The following is a description of a gene set: studied in species Homo sapiens Abnormality of retinal pigmentation Human Gene Set: HP_ABNORMALITY_OF_RETINAL_PIGMENTATION, and this is the list of marker genes: CHM, OCA2, PEX1, TTLL5, DYNC2LI1, UNC119, GMPPB, EYS, ACOX1, MT-ND1, HCCS, PITPNM3, TUBGCP4, PDE6A, MTTP, OPN1MW, WRN, PRPH2, SDHAF1, MT-TK, MSTO1, PEX19, POLR3A, MPV17, RD3 (RD3 regulator of GUCY2D), MKS1, GSS, TRAF3IP1, HK1, ERCC6, ARL2BP, CABP4, MT-TV, ERCC2, MED12, PEX11B (peroxisomal biogenesis factor 11 beta), ATXN7, RPE65, GNAT1, CEP120, FKRP, NRL, CFH, CFAP418, CLCC1, COX8A, TAF2, SOX2 (SRY-box transcription factor 2), MT-TL1, PROM1, RAX2, NCAPG2, AIRE, PRPF3, PHYH, VPS13B, BBS5 (NCBI Gene Id 428), TRIM37, ARSG, PEX13, PCYT1A, COX7B, EDNRB, RBP3, RNASEH1, LCA5, MFSD8, PDE6H, TTC21B, ZNF408, GPR179, TUBGCP6, ARL3, CNGB1, CNGA1, NR2E3, PEX16, SAG, TBC1D20, ALDH1A3, NDUFB11, CP, ARL13B, CACNA2D4 (NCBI Gene Id 93589), PRPF31, NPHP4, IFT43, RMRP, MMACHC (metabolism of cobalamin associated C), HADHB, TRNT1, LARGE1, BBS1, WFS1, DYNC2I2, LYST, SLC24A1, MT-ATP8, RAB3GAP1, SELENOI, EPG5, CDHR1, NOTCH2NLC, NPHP3, MECR (NCBI Gene Id 554211), CEP290, MT-ND4, ZFYVE26, PEX5, IFT140, TOPORS, RPGR, FLCN, HKDC1 (hexokinase domain containing 1), RPGRIP1, AMACR, LMNA, DHX38, CYP4V2 (cytochrome P450 family 4 subfamily V member 2), PRPF4 (NCBI Gene Id 9128), SNRNP200, LZTFL1, ERCC3, DHDDS, OFD1, MT-TW, TTPA, AHI1, RP1, NEK2, ALMS1, RAB18, ARL6 (NCBI Gene Id 84100), KCNJ13, SPATA7, TRPM1 (transient receptor potential cation channel subfamily M member 1), MORC2, SDHB, RP1L1 (RP1 like 1), PEX10, GUCA1B, GNB3, KIAA1549, AHR, OTX2, ERCC8, RP9, KLHL7, EFEMP1, ADAM9, SOX10, PEX2, CA4, ATF6, RGR, SDHD, TUB, IMPG2, PEX6, MT-ATP6, ERCC4, CNNM4, ROM1, SDHA, NYX, DYNC2I1, MT-ND5, TYR, PEX12, RNF216, RPS6KA3, CRB1, INVS, ERCC1, RAB28, TULP1, PLK4, SDCCAG8, MT-TQ, NBN, PRPF8, USP45, ABCA4, JAG1, COA8, GNAT2, ELMO2, APC, MT-CO2, RAX, MC1R, SLC7A14, IDH3B, RAB3GAP2 (NCBI Gene Id 26114), MKKS, HGSNAT (NCBI Gene Id 8119), IDS, MERTK, PUS1, EDN3, CERKL, CFAP410, FAM161A (NCBI Gene Id 84140), MT-CO1, PDE6G, IFT88, RDH12, CBS, ALDH6A1, POMT2, POLG, RRM2B (NCBI Gene Id 50484), GDF6, CACNA1F, SLC45A2, SLC6A6, IQCB1, AIPL1, GRK1 (G protein-coupled receptor kinase 1), ERCC5, POC1B, RDH11, PEX3, OPN1LW, CLRN1, PRPF6, MT-TN, PIEZO2, SUMF1, MT-ND6, DRAM2, POMT1, BBS9, PNPLA6, AGBL5, FLVCR1, ARHGEF18, RNU4ATAC, HADH, TWNK, PANK2, MCOLN1, TTC8, NPHP1, CC2D2A (NCBI Gene Id 57545), HADHA, DHX16, IFT52, NDUFAF1, FSCN2, MITF (NCBI Gene Id 7487), PISD, CFI, MT-TH, CRX, KIF11, IFT80, PEX14, PCARE, TLCD3B, RLBP1, RP2, NGLY1, LAMB2, PRDM10, MAK, PEPD, PRSS56, BEST1, TMEM98, SEMA4A, IDH3A, SIX6, IFT172, GUCY2D, ELOVL4, GRM6, POMGNT1, VPS33A, MT-TS2, KIAA0753, RHO, PEX7, CCDC28B, PDE6B, CLCN3, ALDH3A2, CNGA3, RIMS1, ISCA1, SCAPER, PEX26, RDH5, LRIT3, FLNB, GPR143, CEP164, CNGB3, CAV1, PRCD, PDE6C, BBS2, TNFRSF11B, IMPG1, MT-ND3, AKT1, NMNAT1, CLDN19, ZNF513, TIMP3, SLC12A6, USH2A, KIZ, CTNS, PRDX1, WDR19, CTNNB1, IMPDH1 (NCBI Gene Id 6105), DYNC2H1, SURF1, TUBB4B, CDH3, GUCA1A, REEP6, LRAT, TNFRSF11A, MT-TF, MFRP, PAX6, MT-CO3, VPS41, MT-ND2